The following is a description of a gene set: Mouse Gene Set: MIR_487B_5P Genes predicted to be targets of miRBase v22 microRNA mmu_miR_487b_5p in miRDB v6.0 with MirTarget v4 prediction scores > 80 (high confidence targets). from publication Chen Y, Wang X (PMID 31504780) studied in species Mus musculus, and this is the list of marker genes: Celf1, Dennd1b, Naa30, Zdhhc18, Npepps, Npat, Plp1 (NCBI Gene Id 18823), Foxf1, Mecp2, Usf3, Bmp2, B3galt5, Fam117b, Ly86, Ptprc, Acer2, Ints6, Nfatc1, Epb41l2, Zyx, Ube2d2a, Zfand5, Snx4, Ndufaf4, Grm3, Hpca, Neto2, Ubtd2